Given this list of marker genes F2, F7, TGFB1, ZG16, LUM, MUC5B, DEFA6, ACAN, CSPG5, GPC1, INS, MUC1, PDGFB (NCBI Gene Id 5155), GPC6, BPNT2, TPST1, LRPAP1, CSPG4, GPC5, MUC4, WNT5B, SDC4, F10, SDC3, CGA, MUC17, AGRN, MUC16, MMP14 (NCBI Gene Id 4323), HSPG2, PCSK5, DAG1, MUC5AC, ERO1A, WNT7B, MUC15, WNT6, DEFB1, APP, PROS1, WNT3, DEFB103B (NCBI Gene Id 653671), PRELP, MUC7, GAS6, FURIN, SDC2, PODXL2, GPC3, OGN, VTN, LHB, PDGFA, BGN, MUC12, WNT1, MUC3A, HS3ST1, MUC21, MUC20, DEFB4A, FMOD, BGLAP, F9, PROC, DCN, OMD, WNT4, NCAN, MUC6, WNT5A, UMOD, LALBA, DEFA1B, PROZ, ABCC5, TPST2, NGF, KERA, FGF23, GOLIM4, DEFA1, BCAN, MUC19, GPC2, SDF4, WNT3A, RAB33B, DEFA4, PPIL2, SDC1, MUC2, DEFA5, MUCL1, SOD3, PCSK6, F8, MMP16, VCAN, MMP11, AGRP, MUC13, RHBDF2, DEFA3, GPC4, DEFB103A, WNT7A, here is a description of the gene set: The volume enclosed by the membranes of any cisterna or subcompartment of the Golgi apparatus, including the cis- and trans-Golgi networks. Human Gene Set: GOCC_GOLGI_LUMEN studied in species Homo sapiens